Given this list of marker genes PPCS, ACAT1, PANK4, COASY, PANK2, DCAKD, ACOT7, PANK1, PANK3, PPCDC, here is a description of the gene set: Human Gene Set: GOBP_COENZYME_A_BIOSYNTHETIC_PROCESS studied in species Homo sapiens The chemical reactions and pathways resulting in the formation of coenzyme A, 3'-phosphoadenosine-(5')diphospho(4')pantatheine, an acyl carrier in many acylation and acyl-transfer reactions in which the intermediate is a thiol ester.